The following is a description of a gene set: Mouse Gene Set: GOCC_CALCIUM_CHANNEL_COMPLEX An ion channel complex through which calcium ions pass. species: Mus musculus, and this is the list of marker genes: Ryr1, Slco6c1, Cacna2d3, Catspere1, Micu3, Stac3, Cacnb4, Catsper1, Cacna2d1, Efcab9, Trpc5, Ryr2, Smdt1, Fkbp1a, Akap6, Trpv6, Calm1, Cacna1s, Cacna2d4, Cacna1d, C2cd6, Micu1, Hspa2, Cacnb2, Catspere2, Catsperz, Mcu (mitochondrial calcium uniporter), Ryr3 (ryanodine receptor 3), Cacna2d2, Catsperg2, Cacna1b, Ptpa, Cachd1, Cacnb3, Catsper4, Cacng2, Pkd1l1, Trpc4, Pkd2l1, Catsper2, Fkbp1b, Mcub, Pde4d, Sestd1, Calm2, Cacna1e, Cacna1c, Calm3, Tmem262, Cacna1a (calcium channel, voltage-dependent, P/Q type, alpha 1A subunit), Catsperd, Pkd1, Cacng7 (calcium channel, voltage-dependent, gamma subunit 7), Cacng8, Tmem249, Cacna1f, Catsper3, Cacng6, Trdn, Cacna1h, Cacnb1, Micu2, Catsperb, Trpv5, Cacng4, Cacng1, Catsperg1